Given this list of marker genes SGO1, CLDN23, SURF6, XBP1, KCNJ3, ZC3H12B, RBM41, ERCC6L2, HECW2, RORA, CAMK1D, SYT1, FUT8, ATL1, CIMIP5, NCOA7, TOMM70, HLA-DRA, SLC9A1 (NCBI Gene Id 6548), TIPRL, BPY2B, GP5, UBE2V2, CLEC4M, ADAM21, MTPN, SGCB, CA7, BPY2, CTNNA2, NAA30, LHFPL3, B3GALT2, DCAF8L1, RGS7BP, YWHAH, AKAP3, LDB2, INO80D, SAXO2, INTS6L, BPY2C, STAG1 (NCBI Gene Id 10274), MEIOC, EP300, CDH13, RSPO1, SLC37A2, POP4, PCDH9, ZNF681, PBX3, PDE8B, MIGA2, HOXC10, ARID5B, CACNA1B, here is a description of the gene set: studied in species Homo sapiens Genes predicted to be targets of miRBase v22 microRNA hsa-miR-5011-3p in miRDB v6.0 with MirTarget v4 prediction scores > 80 (high confidence targets). from publication Chen Y, Wang X (PMID 31504780) Human Gene Set: MIR5011_3P